The following is a description of a gene set: species: Homo sapiens Catalysis of an oxidation-reduction (redox) reaction in which a CH-NH2 group acts as a hydrogen or electron donor and reduces an oxygen molecule. Human Gene Set: GOMF_OXIDOREDUCTASE_ACTIVITY_ACTING_ON_THE_CH_NH2_GROUP_OF_DONORS_OXYGEN_AS_ACCEPTOR, and this is the list of marker genes: LOXL2, DDO, VCAM1, LOXL3, AOC3, MAOA, AOC2, PNPO, LOXL1, LOXL4, RNLS, MAOB, AOC1, LOX, DAO, IL4I1